The following is a description of a gene set: studied in species Homo sapiens Modulates the activity of a cyclin-dependent protein serine/threonine kinase, enzymes of the protein kinase family that are regulated through association with cyclins and other proteins. Human Gene Set: GOMF_CYCLIN_DEPENDENT_PROTEIN_SERINE_THREONINE_KINASE_REGULATOR_ACTIVITY, and this is the list of marker genes: CCNT1, CCND3, CCNF, CDK5R1, CCNB3, CDKN1B (cyclin dependent kinase inhibitor 1B), CASP3, CCNE2, CDKN2D, MNAT1, CDK5R2, ANKRD42, CDKN1A, CNPPD1, CKS1B, CCNG1, KAT2B, CCNJ, CKS2, CCNB2, CCNO, CDKN2B, CCNP, CCNL1, HEXIM2, CCND1, CCNY, INCA1, CDK4, CCNB1, CCNI, CCNH, CCNL2, CDKN2C, CCNK, CCNC, CCNT2, CDKN1C, CCNJL, CCNA1, CDKN2A, CCND2, CCNQ, CCNE1, CCNG2, HEXIM1, CCNA2, CCNI2